The following is a description of a gene set: Mitotic Telophase/Cytokinesis species: Mus musculus Mouse Gene Set: REACTOME_MITOTIC_TELOPHASE_CYTOKINESIS, and this is the list of marker genes: Kif23, Wapl, Kif20a, Smc3, Stag2, Mau2, Pds5a, Smc1a, Stag1, Pds5b, Rad21, Nipbl, Plk1